Given this list of marker genes Ska3, Ndc80 (NDC80 kinetochore complex component), Mad2l1bp, Usp44, Tpr, Prpf4b, Anapc15, Ccnb1-ps, Etaa1, Brca2, Knl1 (kinetochore scaffold 1), Anapc15-ps, Babam2, Ppp1r10, Brca1, Nek1 (NCBI Gene Id 52422), Cdca8, Tti1, Gen1, Mad1l1, Incenp, Birc5, Atf2, Rfwd3, Wdr76, Fbxo4, Chek2, Mad2l1, Bard1, Map3k20, Brd4, Rad51, Rnaseh2b, Aurka, Prap1, Lcmt1, Prox1, Cul4a, Rpa2, Xrcc3, Ska1, Aurkb, Brcc3, Fem1b, Hsf1, Zwint, Ccnb1, Dync1li1, Cry1, Dusp1, Ccar2, Cdk5rap2, Pcid2, here is a description of the gene set: Any process that modulates the frequency, rate or extent of cell cycle checkpoint. Mouse Gene Set: GOBP_REGULATION_OF_CELL_CYCLE_CHECKPOINT species: Mus musculus